Given this list of marker genes POU6F1 (NCBI Gene Id 5463), GRK2, PCMTD2, HCST, SUSD1, SASH3, LPP-AS2, EMB, SELPLG, BCL3, S1PR4, BANK1, TK1 (thymidine kinase 1), BMP2K, CCDC82, MXI1, KIZ, ADAMTS10, CNR2, AKR1B10, ARHGAP19, MAP4K2, PNLIP, SERINC3, ETS1, CD79A, SH3BP1, FLI1, KDM7A (NCBI Gene Id 80853), TTC5, INCA1, RASSF2, SIGLEC10, SLC25A53, CYB561A3, PHF13, BAZ2B, ACAP1, MBD4, CTSS, SORD, RFLNB, PTPRE, LNPEP, SSH2, CCDC88C, DENND1C, RPS6KA5, CD3G, LAPTM5, ITGA4, AKT3, DMPK, GCOM1, CTSW, RASA3, AP3B1 (adaptor related protein complex 3 subunit beta 1), TNFAIP8L2, CNN2, AKNA, ABCA7, CEMIP2, CD82, SYK, RNASE6, SMPDL3A, RASGRP2, YPEL3, HELZ (helicase with zinc finger), IP6K1, MPEG1, MS4A6A, FCGR2B, TSPAN13, BNIP3L, TUT7, MSRB3, CCNG2, ABCD1, RBM38, ARHGAP45, ABCG2, HLA-DOB, JUND, CDC42EP3, SEMA4B, FAM107B, PHLDA3, TBXA2R, RIN3, LRRC8C, POLR3GL, CD3D, LPAR6, TMEM86A, ARID3B, ARHGDIB, C19orf38, AFF1, PPM1D, SIRT4, FRYL, GTPBP2, GMFG, CDON, TCP11L2, ARID5A, PLD4, NOXO1 (NCBI Gene Id 124056), GAB3 (GRB2 associated binding protein 3), PLEKHA2, SELL, H3-5, SMC6, IFNGR2, TUBB1, DGKA, TBC1D10C, ITGB3, SGMS1, HEXB, TSPYL4, ATOSA, KMT5C, NOTCH2, PDE2A, SEMA6D (semaphorin 6D), FOXO4, CBL, ICOSLG, GANC, RP2, UBA7, TP53I11, MRTFA, IFT80, ATP13A2, LPCAT2, SMIM14, ITK, CREBRF, PIAS3, BICRA, KLRD1, CTSF, DOCK2, PECAM1, N4BP3, GDI1, SLC12A6, ZNF414, KLHL14, RCSD1, CORO1A, DENND3, SPATA6, KIAA0040, LEPROT, P2RY14, RNF167, SIDT1, PGAP1, CYTH1, MYLIP, UPB1, DCK (NCBI Gene Id 1633), WNT10A, RERE, PDE3B, P2RY10, N4BP2L1, TMEM123, C1orf21, CCND3 (cyclin D3), TLR1, ARHGEF1, PHF1, CD38, CHST12, TRAF5, KLHL24, EMP3, STK10, ZNF608, GRAMD2B, CD1D, KLF2, RNASEL, PITPNM1, HPSE, ABI3, PIK3CG, CREBL2, POU2AF1, ARHGEF18, CYBB, STK17B, TYROBP, MZB1, INPP5D, here is a description of the gene set: Human Gene Set: GSE43863_DAY6_EFF_VS_DAY150_MEM_LY6C_INT_CXCR5POS_CD4_TCELL_DN studied in species Homo sapiens Genes down-regulated in Ly6c int CXCR5+ CD4 T cells: effector during acute infection of LCMV versus memory. from publication Hale JS, Youngblood B, Latner DR, Mohammed AU, Ye L, Akondy RS, Wu T, Iyer SS, Ahmed R (PMID 23583644) CD4 T follicular helper (Tfh) cells provide the required signals to B cells for germinal center reactions that are necessary for longlived antibody responses. However, it remains unclear whether there are CD4+ memory T cells committed to the Tfh lineage after antigen clearance. Using adoptive transfer of antigen-specific memory CD4+ subpopulations (based on CXCR5 and Ly6c expression)in the LCMV infection model, we found that there are distinct memory CD4+ T cell populations with commitment to the Tfh and Th1 lineages. Our conclusions are based on gene expression profiles, epigenetic studies and phenotypic and functional analysis. The gene expression profiles of virus-specific CD4 T cell subets at effector and memory stages is presented here.